Given this list of marker genes UBB, ITCH, ATG12, RNF135, TRAF3, RPS27A, IFIH1, UBA52, TRIM4, UBE2K, HERC5, TBK1, NLRC5, TRIM25, PIN1, UBE2D3, CYLD, MAVS, RNF125, OTUD5, UBE2L6, TAX1BP1, RIGI, NLRX1 (NLR family member X1), IRF3, ATG5, UBE2D1, UBA7, PCBP2, TNFAIP3, UBE2D2, UBC (ubiquitin C), IKBKE, ISG15, RNF216, here is a description of the gene set: part of: DDX58/IFIH1-mediated induction of interferon-alpha/beta species: Homo sapiens Reactome Pathway: Negative regulators of DDX58/IFIH1 signaling As with other cytokine systems, production of type I IFN is a transient process, and can be hazardous to the host if unregulated, resulting in chronic cellular toxicity or inflammatory and autoimmune diseases. RIG-I-mediated production of IFN can, in turn, increase the transcription of RIG-I itself, thus setting into motion an IFN amplification loop, which if left unchecked, could become deleterious to the host. This module mainly focuses on the endogenous negative regulation of the RIG-I-like receptor (RLR) family proteins RIG-I (DDX58) and MDA5 (IFIH1).